The following is a description of a gene set: The aggregation, arrangement and bonding together of constituent RNAs and proteins to form the small ribosomal subunit. Mouse Gene Set: GOBP_RIBOSOMAL_SMALL_SUBUNIT_ASSEMBLY studied in species Mus musculus, and this is the list of marker genes: Rps5, Pwp2 (PWP2 periodic tryptophan protein homolog (yeast)), Rps25, Rps6-ps4, Mcat, Mrps7 (mitchondrial ribosomal protein S7), Rps27, Fau, Rps14, Rps6, Rps19, mt-Rnr1, Eral1, Rpsa, Abt1, Mettl17, Prkdc (NCBI Gene Id 19090), Rps15, Rps28, Rrp7a, Xrcc5, Rps27l